Given this list of marker genes JUP, PTDSS1, TWIST2, NSDHL, TBX5, CHUK, FAT4, CDH3 (NCBI Gene Id 1001), FGFR2, GPC4, GLI3, PIEZO2, BBS2, PAX3, DCHS1, TWIST1, TP63, LRP4, WDR19, PPP2R3C, SHH (sonic hedgehog signaling molecule), IRF6, SETBP1, FANCF, DSP, MEGF8, NEDD4L, LMBR1, SOST, CCBE1, MYH3, KAT6A, NECTIN1, H4C9, CDC45, FRAS1, HOXD13, NECTIN4, MAB21L2, NOG, GJA1, CDH11, CHSY1, EFNB1, GPC3, CPLANE1 (ciliogenesis and planar polarity effector complex subunit 1), ORC1, KCTD1, RTTN, ROR2, PORCN (NCBI Gene Id 65017), CACNA1C, SALL1, WDPCP, TMEM53, here is a description of the gene set: Cutaneous finger syndactyly A soft tissue continuity in the A/P axis between two fingers that extends distally to at least the level of the proximal interphalangeal joints, or a soft tissue continuity in the A/P axis between two fingers that lies significantly distal to the flexion crease that overlies the metacarpophalangeal joint of the adjacent fingers. Human Gene Set: HP_CUTANEOUS_FINGER_SYNDACTYLY species: Homo sapiens